Given this list of marker genes ENPP1, SLC34A3, TCF4, NPR3, CCDC115, SLC34A1, MST1, NPR2, ESR1, VCP, ABCC6, SEMA4D, CYP27B1, GPR35, CYP2R1, CTNS, DMP1, here is a description of the gene set: Human Gene Set: HP_ELEVATED_TISSUE_NON_SPECIFIC_ALKALINE_PHOSPHATASE studied in species Homo sapiens An abnormally increased level of alkaline phosphatase, tissue-nonspecific isozyme in the blood. Elevated tissue non-specific alkaline phosphatase